The following is a description of a gene set: Human Gene Set: GOBP_EPITHELIUM_DEVELOPMENT studied in species Homo sapiens The process whose specific outcome is the progression of an epithelium over time, from its formation to the mature structure. An epithelium is a tissue that covers the internal or external surfaces of an anatomical structure., and this is the list of marker genes: GBX2, TGFB1 (NCBI Gene Id 7040), DNPH1, CPS1, DVL2, TWIST1, KRT78, TBX20, KRT25, GRXCR2, CASR, MYO6, GMNC, FAM20C, HOXA11, IL31RA, ALDH1A2, STAT6, TGM2, ACAT1, ARID4A, FZD2, RHOA, CRYAA, TOLLIP (NCBI Gene Id 54472), KRT39, DNAAF1, MIR1-1, MIR18B, CAT, CNFN (NCBI Gene Id 84518), KRT6C, FOXB1, SPRR4, PTCH1, KRT82, ACADVL, GREB1, AKR1C1, NTRK3, RILPL2, SLC39A7, FGF1, BMP7, MYO9A, PROM1, GSK3A, NDP, CLDN1, HOXD13, DHRS9, ADAM17, MTSS1, KCNE1, CDH5, BARX1, HOXB2, SPECC1L, ATOH8, PDGFA, TEAD2, ASAH1, EZH2, LTA4H, CD24, GATA1, IL6ST, CLRN2, RIPK4, RAPGEF2, LGR4, WNK4, MYO1E, ERCC2, KRTAP6-2, RAB10, DLX5, CDH3, EDNRA, KRT38, WNT7A, IFT172, BBS4, KRT72, MIR181B1, PLK4, CPT1A, KLHL3, PDCD10, HDAC2, FGF20, NF1, MSGN1, KRTAP6-3, ITGAX, RAPGEF3, DLG1, TIMELESS, EDA, ATP7A, LLGL2, PYY, RBM15, TBXT, S1PR3, SERPINB5, HOXA5 (NCBI Gene Id 55953), PKHD1, NPR2, KLF15, IL20 (NCBI Gene Id 50604), AJUBA, MIR518B, ARL13B, CTHRC1, GJA1, CYP27B1, GPR4, TFAP2B, KIF26B, ROCK2 (NCBI Gene Id 9475), KAZN, FUZ, HDAC3, FSHR, WHRN, TMEFF2, BMP4, ID4, FOXI3, RET, EDF1, GJA5, SLC4A7, ITPK1, TBX4, GORAB, WNT6, PLXND1, HOXB4, TNFRSF1A (NCBI Gene Id 8077), PCNA, HES7, TRADD, IRX3, AR, ZFP36L1, WDR77, DSP, FOXF1, ID2, EREG, MYADM, LCE2A, POU3F2, PIAS4, CBY1, RGMA, CTSB (NCBI Gene Id 3896), MAFG, DLG5, NGFR, CTNNBIP1, TBC1D32, PHACTR4, MYC, DSPP, LBH, PUM2, PSAP, FZD5 (NCBI Gene Id 81561), KPRP, EPPK1, TCF15, TCTN1, PLEC, SRC, IRX1, GZF1, C1orf54, DLL4, SIRT6, TLR9, TAF10, MESP2, BMP6, EP300, FOSL2, ELOVL1, BAD, NFATC4 (nuclear factor of activated T cells 4), PTK7, MEGF8, KLF2, KDM2B, IER3IP1, TGFB1I1 (transforming growth factor beta 1 induced transcript 1), MSN, MAPK1 (mitogen-activated protein kinase 1), SOX17, MIR181A2, NOTCH1, NHERF1, ALOX15B, PECAM1, APAF1, YAP1, TMEM107, SLITRK6, BCL2, LUZP1, KRT34, GATA4, CRB2, IL1B, HIF1A, RAB1A, IL18, RDX, AKR1C3, LCE1E, KRT1, CDK6, NUP133 (NCBI Gene Id 55746), PLAAT3, NFKBIZ, TMOD1, AP3B1, WNT2B, APELA, NODAL, AQP1, BRCA2, SALL4, KRT28, CREB1, TBX2, MIR150, SHH, LCP1, WNT3A (Wnt family member 3A), ROBO2, TFAP2A, HEY2, HAPLN2, OTP, VAX1, ADAM7 (NCBI Gene Id 8756), PPP1R16B, ENAM (enamelin), JAG2, FLG2, CD44 (CD44 molecule (IN blood group)), COL4A1, XDH, CYP1A1, ACTG1, KRT79, STMN1, GSK3B, ZNF703, TCF21, FLNA, IGF1, MIR21, ZFP36, DLX6, CAV3 (caveolin 3), APCDD1, BMP5 (bone morphogenetic protein 5), SULT2B1 (NCBI Gene Id 6820), MMP14, ARG2, ITGB3, INHBA, NFIB, DSG4, PSEN1, CSF1, SPINT1, LCE7A, WNT11, RPTOR, RBPJ (NCBI Gene Id 51580), BBS5, COL18A1, POU3F3, PAFAH1B1, LCE3D, FEM1B, CLDN4, CHD7, LATS1, LIAS, NSDHL, FER (NCBI Gene Id 2241), TJP1, MTHFD1L, ESR1, INTU, SPINK5, CDH2, DMBT1, SMAD7, CTNND1, MIR199B, PFN1, ACVRL1, NTF4, CELSR1, KRIT1, SIPA1L3, TRAF3IP1, CASP3, CDKN2A, CCND1 (NCBI Gene Id 893), WT1, NOTCH2, HBEGF (NCBI Gene Id 1839), RARB, AFDN, ESRP1, SPRR2B, LCE3B, CCDC39, SYNE4, SOX10, ASTN2, DNASE1L2, MACROH2A2, TGM1, CD109, ECE1, TP53, RCN3, MIR302A, PTCH2, CCM2, PRKACA, NRP1, DEUP1, RYR2, NR0B1, LOXL3, ATF4, TMEM132E, SPRR1A, PDPK1, CAMSAP3, EFNB2, CEP152, POU4F3, HPSE, AJAP1, NKX2-2, GSTA2, ZMPSTE24, TECTA, TMEM59L, ADM, ACVR1, KRT80, NUP210L, TCAP, DMRT1, CCNO, MAGI1, CLDN3, GATA5, FOXN1, PLS1, SOX21, JAK2, PTPRS, PLOD3, TP73, NME2, CCDC88C, E2F7, SETDB2, NOG, EYA1, FOXA1, KRT16, ITGB1, NPHP3, JAG1, ALOXE3, PLA2G10, LAMB2, SRF, C2CD3, TAGLN, HOXC13, NEUROD1, SNAI1, VEZF1, GATA3, GDF2, OPA1, GLI1, FOXP1, OVOL1, UPK1A, ELMOD3, MEF2C, LIPN, BMAL1, CDKN1A, HNF1B, TBX5, DLL1, EGF, KAT2A (NCBI Gene Id 2648), CLASP2, KRT14, GRHL3, KRT81, WNT9B, NOM1, SLC40A1, SPRR2E, FN3K, KRT26, SMAD5, DLC1, KRT10, KLF4, TBX6, LATS2, LRP2, TST, WDR1, SH3BP1, IFT57, ERBB4, TRIM16, LAMA5, ARID4B, CES1, BMI1, WNT3, FRAS1, MYD88, LCE1B (NCBI Gene Id 353132), MCIDAS, ENG, SKI, ACTL8, FZD6, GDF3, FSTL1, SLC22A6, WDPCP, NPHS2, EXT1, DMRT2, WNT2, RAP2A, PALS1, MTHFR, KRT76, GRSF1, MESP1, GDF7 (NCBI Gene Id 8873), CLOCK, SPRR1B, ADAMTSL2, PITX2, TDRD7, COBL, CYP26B1, LRP5, TBC1D20, WWTR1, PAK1, REST, RELA, KDM6B, SOX18, WNT16, MINAR2 (NCBI Gene Id 100127206), ZDHHC7, ACVR2B, ELF5, BMPER, HAND2, PITX3, ERRFI1 (ERBB receptor feedback inhibitor 1), NR5A1, LDB2, DACT2, IL17A, GNA13, CERS3, ASB2, PELO, BRSK2, CDSN, LCE1A, INSM1, BMPR2, KRT5, OVOL2, FOXE1, PDGFB, PLCB1, RBBP6, IFT20, NPY (neuropeptide Y), HEG1, SPRR2G, NDRG4, FGF8, FOXC1, CER1, ZBED2, EPHA7 (NCBI Gene Id 2045), CYP7B1, MSX1, LZTS2, SALL1, LGALS3, CEBPA (NCBI Gene Id 1050), CLDN19, VDR, NR2F2, ABL1, VSIG1, DUSP10, GDF11, STOX1, SMAD4, NLE1, GSTK1, RAC1, MAP2K1, POGLUT1, PRKDC, CLIC4, RASIP1, RTN4, MIR495, POFUT1, PLXNA1, PRDM1, RHCG, KRT83, GSTM3, LCE3A, TCHH (trichohyalin), SOD1, SFRP4, LCE4A, TTBK2, MAFB, EPCAM, SEMA4C, HS2ST1, LFNG, KLK5, AHI1, FKBPL, TFAP2C, AQP11, PPP2R3A, HS3ST3A1, PPARG, GREM1 (gremlin 1, DAN family BMP antagonist), FLRT3, EZR, DCHS1, ONECUT1, TSC2, KRT86, TULP3, VANGL2, SAV1, RARA, MIR221, MIR16-1, CAV1, PTK6, AMOTL2, PRLR, CRYGD, TAGLN2, KRT12, GSTA1, PBX1, MIR34A, ITGAV, FNDC3A, SOX9 (NCBI Gene Id 6662), SULF1, CDKN1B, FERD3L, PLET1, KRT31, KRT3, FIGNL2, MIR204, DLL3, ORAI1, AGTR2, SULT1B1, CA9, KRT75, ETV4, SPRY2, KRT37, LORICRIN, FREM2, ALDOC, RDH10, MAP2K2, IQGAP3, FOXJ1 (NCBI Gene Id 2302), ZNF800, LHFPL5, NCKAP1, OSR1, FOXN4, AKT1, SKIL, PKD2, TBX3, LHX1, CD63, LCE1C, SLC38A8, MARCKS, CLRN1, IRX2, POU3F1, FGF10, PKP1, MEOX1, BASP1, ATP2C2, PRICKLE1, PGR, STRC, THRB, SAPCD2, KRT33A, FERMT2, VIL1, MSX2, RIPPLY1, AGT, MACROH2A1 (NCBI Gene Id 9555), FRZB, IRF6, RHOC, BLOC1S6, NPHS1, SIX4, RPGRIP1L, HSF4, CLDN5, MAGED1, RBM4, NCOA3, ZIC3, PIK3CD, FLG, TRPC4AP, CDX1, ABI2, XBP1, TACSTD2, BTBD7, BCR, UGCG, CLUAP1, PLAAT4, ZEB2, SERPINE1, CC2D2A, HGF, B4GALT1, PHLDB2 (NCBI Gene Id 90102), CITED1, MTOR, FGF2, TNMD, RREB1, UMOD, STC1, FGF7, TMEM79, EMX1, EPAS1, RARG, SERPINE2, SCUBE1, ARX, SLC4A5, AMPD2, SGPP1, KDR, TMEM231, BRD2 (bromodomain containing 2), CDKN1C, CLASP1, FZD3, SFN, PERCC1, NR5A2, IFT52, PRKCH, EDNRB (endothelin receptor type B), FOXF2, NFE2L1, CNN3, KRT13, SPRED3, PROX1, TMEM38B, IHH, CRYGS, IFT74, IGFBP5, PROC, SLC9A2, KRT6A, TGM3, ASXL1, BCCIP, RAB1B, KRT9, ROCK1, SLC44A4, KRT2, PPP1R12A, ROBO1, FGFR1, CDC42, CEBPB, LIN7C, KRT17, SSBP3, SLC9A4, UPK1B, SOS1, WDR83, EPB41L5, PCK2, PTEN, FAT1, HEY1, JUN, BMPR1A, GCM1, CTNNB1, BDH2, STAT5B, TRIOBP, UPK2, WNT1, IFT122, NOTO, PTPRO, SPRR2F (NCBI Gene Id 6705), CDK1, SLC39A12, ALOX12B, EGFR (NCBI Gene Id 1956), ID3, NPNT, ALOX12, TOR1A, LCE2D, C1GALT1, PCDH8, TNC, BCL11B, TRIM71, CXCL10, LAMA1, KRT71, ABI1, LBX1, RNF220, EHF, CLCN2, NOTCH4, SOX11, IVL, CEP290, CEACAM1, TBX18, DLX3, CFL1, EXPH5, HOXB13, SIX2, TSC1, HDAC1, RAP1A, GATA2, PODXL, STIL, PDE2A, SMARCB1, EVPL, TMEM100, SPINT2, XRCC2, MIR99B, WNT10B (NCBI Gene Id 82499), COL5A1, GSC, SMAD3, PAX8, TFCP2L1, LDB1, GPR161, SPRR3, WNT5B, GAL, PPP3CA, CASP14, SPRR5 (NCBI Gene Id 110806278, small proline rich protein 5), BRSK1, HOXD11, TJP2, FZR1, ACVR1B, NEUROG3, NPPC, FOXP3, EXTL3, MKKS, ANXA7, MED1 (NCBI Gene Id 9327), BSG, FASN, KRT4, MAFF, BFSP2, F11R, YIPF6, SEMA3E, FOXP2, EPHA2, C3, ESRP2, KAT5, STAT1, RAB13, HAND1, ANXA4, CD34, WNT7B, STK4, ALX4, MED12, MRTFA, GDNF, MIR541, PALLD, CBFA2T2, DVL1, AKT2, TMIGD1, RAP2C, HOXA13, SUFU, MICAL2, ETV2, KRT32, LCE6A, PRKD2, IPO7 (NCBI Gene Id 10527), GRB2, IL10, NKX3-1, STARD7, OVOL3, RSPO3, FOXQ1, KEAP1, RAP2B (NCBI Gene Id 5912), RFX6, KRT74, MANSC4, GRHL1, GSDME, MMP12, KRT84, USH1C, TRIM28, GRHL2, COL6A1, NF2, SPRY1, ALX1, DAG1, ZNF750, PGK1, PDZD7, MFSD2A, EDN1, KRT85, MYO7A, NKX6-2, KRT27, PAX6, RBBP9, VASP, CDH23, HESX1, HSD17B4, RSPO2, SHARPIN, PRKX, ROBO4 (roundabout guidance receptor 4), TJP3, USH2A, KRT73, AIMP2, NKX2-1 (NCBI Gene Id 7080), LRG1 (leucine rich alpha-2-glycoprotein 1), KRT33B, PLXNB2, KANK2, LCN2 (NCBI Gene Id 3934), SIDT2, OPHN1, NUMA1, ICAM1, FZD1, F2RL1, CHRD, SEMA3C, NTRK1, AREG, TRAF6, APOLD1, STRA6, NTN1, NRG1, TPRN, TMED2, SIX1, ITGA5, DSC1, B9D1, GLI2, MYCL, SAFB2, NR3C1, S1PR2, FOXD1 (NCBI Gene Id 2297), FGFR2, BTRC, FRS2, ACTA2, ZDHHC21, RAP1B, RAB25, GRXCR1, DLG3, ASCL3, LIF, VCL, TGIF1, ADAM9, PHGDH, PKD1, FOXC2, GREB1L, HS3ST3B1, SOX8, CCDC78, PIP5K1A, PAX7, ANKRD24, ATM, LCE3C, BHLHA15, CSMD1, LHX3, BMP2, MAF, ROS1, MIR200C, SPRED2, LCE3E (NCBI Gene Id 353145), FKBP8, CSF1R, S1PR1 (NCBI Gene Id 51546), TIE1, LIPM, WNT10A, GET1, MAGI2, VEGFA, IFT80, PYGO2, TBX1, SOX4, GBA1, ADAMTS16, WNT4, KDM5B, ARHGAP12, ANXA1, NKX2-6, RALA, CRLF1, HNRNPH3, TMEM135, PERP, S100A7, ID1, CA2, AKR1C2, OPN3, FOXL2, CDX2, LIPK, SLIT2, RHOB, MYSM1, PCK1, PPP1CA, KRT35, HTN1, ARHGAP35, VDAC1, FA2H, REG3G, RIPPLY2, MSI1, HOXA7, CD2AP, SLC39A2, BTG1 (NCBI Gene Id 694), LEF1, GPC3, PAX2, IL13, KRT23, KDF1, ETV5, NKD1, FOXJ2, AQP3, ONECUT2, KLF7, DDR1, STAT5A, LBX2, TIGAR, IQGAP1, RAD51B, MIR125B1, MDK (NCBI Gene Id 4192), TSG101, RFX3, COL2A1, SDC4, RAPGEF6, APLNR, MCOLN3, MMP2, GLI3, CSNK2B, LCE2B (NCBI Gene Id 26239), KRTAP6-1, RAPGEF1, MIR29B1, SIX3, SPDEF, MIB1, E2F4, ITGA2, SMO, TMPRSS11F, MTHFD1, MIR15B, PLAAT1, CBR1, GPAT4, TGFB2, MYF5, CCDC40, TNF, KRT40, CASP6, CRYGB, ALDH1A3, TGFBR2, SPRED1, FOXH1, E2F8, PML (NCBI Gene Id 5371), SCRIB, LSR, LRP4, HES1, MYCN, ABCB1, PPP3R1, SCEL, CDK20, FZD4, PKP3, EXOC5, TP63, KRT15, CCL11, NKX6-3, HMGA2, PPHLN1, FOXE3, SOSTDC1 (NCBI Gene Id 25928), PPL, SMAD6, CTSZ, GPX1, MET, SMAD2, CCDC103, ARHGAP24, TNFRSF19, CD151, ILK, HYDIN, PSAPL1, TPP1, AGR2, NTN4, LMO4, ST14, NUP50, ADIPOQ, DKK4, DKK1, KRT7, MEOX2, PDE4D, FZD7, KRT19, IKBKB (inhibitor of nuclear factor kappa B kinase subunit beta), HEYL, KLK14, VIM, RPS7, ADAMTS12, BCL10, NRARP, AMBRA1, MYF6, DZIP1L, CITED2, SIM1, HOXB5, CYSRT1 (NCBI Gene Id 653325), ERCC3, KRT24, KCNQ1, SPRR2D, THRA, GNAS, KRT36, HHIP, TTC8, SRSF6, KLF5, ZNF358, NSUN2, KIF20B, ZEB1, EDAR, PAX4, SNAI2, FST, GATA6 (GATA binding protein 6), LHX2 (LIM homeobox 2), FRMD6, PHB2, EN1, AIRE, NPHP1 (nephrocystin 1), REG3A, BFSP1, RHEB, CEP63, ITGB5, ADD1, MKS1, NKX6-1, SFRP1, DACT1, STK3, FLNB, EPHA4, KRAS, FERMT1, KRT20, MIR10A (NCBI Gene Id 406902), ATRX, WNT5A, FAM3C, GLMN, PLXNA2, MAP1B, TXNIP, CSTA, IFNG, LIPA, HES5 (hes family bHLH transcription factor 5), LCE5A, MMP9, SMAD1, TNFSF11, MARVELD2, TMC1, PALB2, AXIN2, CIMAP3, SLC22A1, DEAF1, PTER, CALB1, BBS7, ABCA12, POF1B, ACER1, VEGFC, ATP6AP2, POU2F3, LGR5, BAX, SEC24B, CARMIL2, WDR19, AKR1B1, LCE1D, ATOH1, NKX3-2, SOCS3, STARD13, RNF207, ASCL1, FOLR1, UPK3A, PRKACB, PLXNA4, ACTB, CTSH, PDPN, SFRP2, RILPL1, CDHR2, KRT6B, ADAMTSL4, SCX, ARHGEF26 (NCBI Gene Id 26084), HOXB7, BLTP1, KRT77 (NCBI Gene Id 387860), LCE2C, CECR2, MMRN2, DSG2, HRNR, TUBB, PDX1, IFT140, DAB2, LCE1F, PIH1D1, NAGLU, SETSIP, JHY, NKX2-5 (NK2 homeobox 5)